Given this list of marker genes MORF4L1, SUCLG2, EID1, ALG8, VDAC2, ILF2, CSDE1, PTP4A1, BTBD3, RHOB, SELENOP, MX1, RHEBP1, SSR3, PSENEN, ETF1, SRP72, SEPTIN10, UQCRFS1, ATP6V0E1, ARF1, YKT6, CANX, CD47 (NCBI Gene Id 961), HNRNPK, DCTD, SELENOT, TAF9, CNIH1, ANKHD1 (ankyrin repeat and KH domain containing 1), YWHAZ, COX7C, EMC7, IFI6, VDAC1, BUD23, here is a description of the gene set: Genes exclusively up-regulated in plasma cells from MM (multiple myeloma) patients but with a similiar expression pattern in the normal cells and in the cells from WM (Waldenstroem's macroblobulinemia) patients. Human Gene Set: GUTIERREZ_MULTIPLE_MYELOMA_UP from publication Gutiérrez NC, Ocio EM, de Las Rivas J, Maiso P, Delgado M, Fermiñán E, Arcos MJ, Sánchez ML, Hernández JM, San Miguel JF (PMID 17252022) The tumoral clone of Waldenström's macroglobulinemia (WM) shows a wide morphological heterogeneity, which ranges from B lymphocytes (BL) to plasma cells (PC). By means of genome-wide expression profiling we have been able to identify genes exclusively deregulated in BL and PC from WM, but with a similar expression pattern in their corresponding cell counterparts from chronic lymphocytic leukemia (CLL) and multiple myeloma (MM), as well as normal individuals. The differentially expressed genes have important functions in B-cell differentiation and oncogenesis. Thus, two of the genes downregulated in WM-BL were IL4R, which plays a relevant role in CLL B-cell survival, and BACH2, which participates in the development of class-switched PC. Interestingly, one of the upregulated genes in WM-BL was IL6. A set of four genes was able to discriminate clonal BL from WM and CLL: LEF1 (WNT/beta-catenin pathway), MARCKS, ATXN1 and FMOD. We also found deregulation of genes involved in plasma cell differentiation such as PAX5, which was overexpressed in WM-PC, and IRF4 and BLIMP1, which were underexpressed. In addition, three of the target genes activated by PAX5 - CD79, BLNK and SYK - were upregulated in WM-PC. In summary, these results indicate that both PC and BL from WM are genetically different from the MM and CLL cell counterpart. studied in species Homo sapiens